Given this list of marker genes FOXO1, FAS, CAV1, ATG7, NOX1, here is a description of the gene set: Any process that results in a change in state or activity of a cell (in terms of movement, secretion, enzyme production, gene expression, etc.) as a result of a stimulus indicating increased oxygen tension. Human Gene Set: GOBP_CELLULAR_RESPONSE_TO_HYPEROXIA studied in species Homo sapiens